Given this list of marker genes Zfp334, Poc1b, Ppfia1, Tmem220, Zfp934 (NCBI Gene Id 77117), Rbm11, Fign, Slc16a10, Ube2d2a, Mfsd8 (major facilitator superfamily domain containing 8), Akirin1, Lmtk2, Zeb1, Sult1d1, Taok1, Frem1, Tbx20, Kcnk5, Aspa, Rab14, Abcb7, Rb1cc1, Mplkip, Igf2bp1, Ccng2 (cyclin G2), Lrrtm3, Pter, Steap2, Elmo1 (NCBI Gene Id 320830), Aqp4, Rap1b, Rbm46, Spin1, Lnpk, Chic1, Inpp5b, D030056L22Rik, Gab1, Washc4, Meioc, Aak1, Rbsn, Flywch1, Zfp955a, Irs1, Snx4, Zfp955b, Tceal8, Kmt2a, Naa35, Ddr2, Mpc1, Gdpd1 (NCBI Gene Id 66569), Fgf14, Chst5, Mybl1, Ppp1r26, Cct4, Mecom, Atp2a2, Prrg1, Ep300, Or8b53, Omg, Ptpn4, Ankrd28, Cxcl10, Pax3, Cyp4v3, Pclo, Pdpk1, Rbms1, Slc4a4, Kcmf1, Ss18l1, Pcdh15, Slc41a2, 4933409G03Rik, Rdh10, Strap, Unc5cl, Trio, Tox3, Hoxc8, Pcdh19, Socs3, Slc35a5, Cpeb4, Fam210a, B3gnt5, Git2, Dll1, Stx3, Sntg1, Mbtps2, Ahcyl1, Ext1, Ghr, Gphn, R3hdm4, Ntng1, Bloc1s6, Asb7 (ankyrin repeat and SOCS box-containing 7), Dio2, Cript, Epdr1, Egr3, Kcnb2, Nfx1, Hhex, Usp33, Atp6v1h, Med12 (mediator complex subunit 12), Uri1, Dbt (NCBI Gene Id 27987), Cyp26a1, Rc3h1, Vps26c, Ccdc171, Arfgef2, Dpy30, Kmt2e, Umad1, Dstn, Gtf2b, Agmo, Rsf1, Gbp9, Atxn3, Lpcat2, Acap2, Kcnk1, Naaladl2, Cnksr2, Vps54, Lair1, Hnrnpm, Secisbp2, D430041D05Rik, Htt, Clec4d, Gabarapl2, Abhd11, Atp8b1, Mycbp2, Gabra1, Pwwp2a, Acbd5, Sema6a, Sptbn1, Sncg, Spry1, Eid2b, Tacr1, Mbd3l2 (methyl-CpG binding domain protein 3-like 2), Rgs7bp, Il17a, Met, Gpr65, Serpinb2, Hlcs, Nadk, Rnd1, Rap2a, Pramel3a, Lum, Ythdf3, Rint1, Ecd, Matr3, Odad2, Gatb (glutamyl-tRNA amidotransferase subunit B), Pard3, Tmco3, Abhd17b, Grhl1, Pdik1l, Vps37a, Ap5m1, Tyr, Serpinb10, Col11a1, Vash2, Dipk2a, Erc2, Tmem47, Pcnx1, Syncrip, Macroh2a1, Pramel3e, Cdk12, Usp7, Tsku, Zfhx3, Ecm2, Gngt1, Parp12, Zfp808, Ptgr3, Eif4b, Golm2, Zhx1, Eaf1, Dclk1, Slc5a7, Csn3, Ric1, Sc5d, Crebzf, Prdm4, Osgin2, Celf4, Adgrv1, Otulinl, Nlk, Tut7, Ehf, Pde3b, Smndc1, Epc2, Nus1, Six1, Fgf9, Ppp2r3a, Pdss2, Rex2, Tead1, Bcl2a1b, Mdfic, Aldh6a1, Epcam, Bcl2a1a, Gucy1a2, Mreg, Slco5a1, Bmt2, Bcl2a1d (B cell leukemia/lymphoma 2 related protein A1d), Pth2r, Nfib (NCBI Gene Id 77183), Fam199x, Ccdc85a, Dpp10, Trak2, Chd1, Gjb2, Fut9, Mat2a, Rnf217, Cfap90, Hycc2, Tlnrd1, Rbm26, Osbpl11, Zc3h12c, Nup155, Tnrc6a, Qki, Rreb1, Dock7, Lrch3, Rho, Cstf2t, Sptlc1, Ebf1, Tbl1xr1, Sms, Lrriq4, Zfp423, Zfp830, Mmp1b, Cry1, Apc, Lrrtm2, Rprd1b, Golga1, Rs1, Edil3, Crisp4, Themis, Sco1 (SCO1 cytochrome c oxidase assembly protein), Htr2c, Adgrl3, Rprd2 (regulation of nuclear pre-mRNA domain containing 2), Mindy2, Il17rb, Jazf1, Nufip2, Tgfb2, Relt (RELT tumor necrosis factor receptor), Srp19, Zfp800, Glyr1, Ccn3, Wnk1, Gjc3, Riok1, Myef2, Apool, Cep126, Efl1, Ltn1, Rgs4, Macir, Cdc73, Zfp518a, Ifrd2, Phip, Rnf34, Lrrn1, Lrp2bp, here is a description of the gene set: from publication Chen Y, Wang X (PMID 31504780) Genes predicted to be targets of miRBase v22 microRNA mmu_miR_421_5p in miRDB v6.0 with MirTarget v4 prediction scores > 80 (high confidence targets). Mouse Gene Set: MIR_421_5P species: Mus musculus